Given this list of marker genes Tspan6, Igsf5, Igfbp4, Areg, Adam12, S100g, Ereg, Serpinb9b (NCBI Gene Id 72011), Mmp12, Clstn2, Igfbp5, Col5a3, Lpar4, Ddit3, Arhgap6 (NCBI Gene Id 270682), Arhgap24, Bmf, Tspan7, Col5a1, Trib3, Serpinb9g, Igfbp3, Atf3, Ctla2a, here is a description of the gene set: species: Mus musculus Mouse Gene Set: WANG_NEOPLASTIC_TRANSFORMATION_BY_CCND1_MYC Cyclin D1 is one of the most commonly overexpressed oncogenes in breast cancer; yet, it is not clear whether cyclin D1 alone is capable of causing malignant transformation of mammary epithelial cells. Here, we show that ectopic expression of cyclin D1 in benign mouse mammary epithelial cells promotes cell proliferation, anchorage-independent growth in soft agar, and tumorigenesis in severe combined immunodeficient mice. To address the possible interaction of cyclin D1 and c-myc in malignant transformation, we used cyclin D1/c-myc dual-expressing clones, which displayed more aggressive and invasive phenotype than cyclin D1-expressing clones. These data provide evidence that overexpression of cyclin D1 or coexpression with c-myc could cause invasive malignant transformation of benign mouse mammary epithelial cells. Furthermore, microarray analysis of cyclin D1 and cyclin D1/c-myc clones showed that these two tumor-producing clones might use distinct invasive pathways. In summary, overexpression of cyclin D1 may commit mammary epithelia to a tumor-prone phenotype in which cooperation with other genes, such as synergy with c-myc, may lead to a more aggressive phenotype. from publication Wang Y, Thakur A, Sun Y, Wu J, Biliran H, Bollig A, Liao DJ (PMID 17440082) Selected genes changed in NMuMG cells (mammary epithelium) transformed by overexpression of CCND1 vs those transformed by overexpression of CCND1 and MYC.